The following is a description of a gene set: Human Gene Set: GOMF_EPINEPHRINE_BINDING Binding to epinephrine, a hormone produced by the medulla of the adrenal glands that increases heart activity, improves the power and prolongs the action of muscles, and increases the rate and depth of breathing. It is synthesized by the methylation of norepinephrine. studied in species Homo sapiens, and this is the list of marker genes: DRD4, ADRA2A, ADRA2C, ADRA2B, RNLS (renalase, FAD dependent amine oxidase), ADRB3